Given this list of marker genes TUBB3 (tubulin beta 3 class III), HAUS4, CNTRL, CCT2, DYNC2I1, CEP41, IFT74, PPP2R1A, RAB3IP (NCBI Gene Id 64325), IFT22, CYS1, CDK1, TUBB1, IFT25, IFT172, NPHP1, CNGA2, CETN2, ATAT1, HAUS5, TMEM67, CEP152 (NCBI Gene Id 23701), IFT70A, LZTFL1, BBS10 (NCBI Gene Id 79738), EXOC1, CKAP5, CDK5RAP2, DYNLRB2, SEPTIN2, CEP192, ACTR1A, TCP1, WDR35, CEP97 (NCBI Gene Id 79598), TUBB, EXOC3, SDCCAG8, KIF3A, SMO, ARL3, PKD2, CEP78, KIF3C, TUBA3C, TTBK2, TUBAL3, RAB11FIP3, TUBA3E, RPGRIP1L, PLK4, C2CD3, CEP76, TUBA1B, PDE6D, FBF1, AKAP9, CEP63, CEP250, ALMS1, EXOC7, IFT88, TUBA3D, CEP131, NEDD1, IFT43 (intraflagellar transport 43), BBS9, BBS2, IFT122, DCTN2, DYNLL1, B9D1, TMEM216, TUBB8B, NPHP4, KIF17, DYNLL2, MKS1, IFT57, YWHAE, HAUS7, TTC21B, INPP5E, CLASP1, AHI1, IFT70B, OFD1, SSTR3, DCTN1, CLUAP1, CEP43, KIFAP3, CENPJ, PKD1, EXOC5, IFT140, PLK1, MKKS, CCT5, ARL6, PCM1, IFT80, HAUS1, CCP110, RHO, UNC119B, IFT81, PAFAH1B1, KIF24, BBS1, TNPO1, CSNK1E, NEK2, TCTN2, TUBB2B, DYNC2LI1, CEP135, RAB8A, TRIP11, TCTN1, TUBG1, CEP162, IFT52, DYNLRB1, HSP90AA1, IQCB1, PCNT, MAPRE1, CEP83, CEP89, TRAF3IP1, GBF1, DYNC1H1, ARL13B, DYNLT2, TUBB4A, CCT4, TUBA4A, TUBB2A, IFT20, HAUS6, EXOC2, DYNC2H1, SFI1, CEP57, TCTN3, SSNA1, TUBA1A, TUBA1C, CSNK1D, WDR19, KIF3B, IFT46, CEP72, ODF2, NPHP3, BBS5, BBIP1, IFT27, TTC8, TUBB6, MCHR1, NINL, DYNC1I2, PRKACA, YWHAG, EXOC4, RAB11A, BBS4, CCT8, DCTN3, BBS7, HDAC6, PRKAR2B, SCLT1, BBS12, DYNLT2B, CCT3, IFT56, CEP70 (NCBI Gene Id 80321), CC2D2A (NCBI Gene Id 57545), DYNC2I2, HAUS3, MARK4, TUBB4B, EXOC8, CEP290, NDE1, TUBB8, HAUS2, ASAP1, EXOC6, CNGA4, ARF4, HAUS8, CEP164, CNGB1, B9D2, DYNLT5, RP2, TUBA8, here is a description of the gene set: Human Gene Set: REACTOME_CILIUM_ASSEMBLY studied in species Homo sapiens Cilium Assembly